Given this list of marker genes FGFR1, CLDN3, ATF4, SLC34A1, SFRP4 (NCBI Gene Id 6424), CRY2, CEBPB, FGF23, here is a description of the gene set: species: Homo sapiens Any process that modulates the frequency, rate or extent of phosphate transport. Phosphate transport is the directed movement of phosphate into, out of or within a cell, or between cells, by means of some agent such as a transporter or pore. Human Gene Set: GOBP_REGULATION_OF_PHOSPHATE_TRANSPORT